The following is a description of a gene set: studied in species Homo sapiens Marker genes curated from the annotated cluster as represented in the Descartes Human Gene Expression During Development database. Human Gene Set: DESCARTES_MAIN_FETAL_PDE1C_ACSM3_POSITIVE_CELLS The gene expression program underlying the specification of human cell types is of fundamental interest. The study authors generated human cell atlases of gene expression and chromatin accessibility in fetal tissues. For gene expression, the study authors applied three-level combinatorial indexing to >110 samples representing 15 organs, ultimately profiling ~4 million single cells. The study authors leveraged the literature and other atlases to identify and annotate hundreds of cell types and subtypes, both within and across tissues. Our analyses focused on organ-specific specializations of broadly distributed cell types (such as blood, endothelial, and epithelial), sites of fetal erythropoiesis (which notably included the adrenal gland), and integration with mouse developmental atlases (such as conserved specification of blood cells). These data represent a rich resource for the exploration of in vivo human gene expression in diverse tissues and cell types. from publication Cao J, O'Day DR, Pliner HA, Kingsley PD, Deng M, Daza RM, Zager MA, Aldinger KA, Blecher-Gonen R, Zhang F, Spielmann M, Palis J, Doherty D, Steemers FJ, Glass IA, Trapnell C, Shendure J (PMID 33184181), and this is the list of marker genes: GSPT2, ZNF85, LINC02241, ANKRD33BP1, FMO6P, ST7L, TNFRSF14-AS1, ZNF480, SLMAP, SRSF3, LINC02935, RN7SL23P, ZNF667 (zinc finger protein 667), VPS45, CCNJ, LIMD1-AS1 (NCBI Gene Id 650067), ZNF350, DLGAP4-AS1, TMEM150B, DBR1, TWSG1-DT, RTF1, CREBBP, LSG1, BRME1, LINC01800, CLDN20, SART3 (NCBI Gene Id 9733), RAB19, ZFR, SCARNA9, VIRMA, ELMO2, LIN28A, DDX4, ZNF512, BRWD1-IT1, RWDD2B, GGACT, MDS2 (NCBI Gene Id 259283), PINLYP, MFSD3, ENSG00000258525, THRB-IT1, UBA2, WNK3 (NCBI Gene Id 65267), PKD1-AS1, TRMT11, SLC16A11 (solute carrier family 16 member 11), H1-10-AS1, CNIH3, LINC00865, ZNF165, PTPRN2-AS1, INO80D, PDXDC2P, ZNF558, ZNF660, ZDHHC3, ARIH1, WDR25, MAMDC2, C3P1, FBN3, DHX37, GUSBP3, SMG1P5 (SMG1 pseudogene 5), HSPA8P15, ZDHHC11B, DPM1, INSRR, C3orf52, ZNF441, IST1, GPRC5D-AS1, FOXP1, OSBPL2, COMMD5, CYP2E1, ZBTB20-AS5, ELP3, RAB43, PTPN23, LINC01852, COL6A4P2, ZNF876P (zinc finger protein 876, pseudogene), RASSF6, FXYD6-FXYD2, TFCP2L1, STPG2, FBXW12, TMEM213, ORC5, FZD4-DT, PDSS2, DDX19B, RPS3AP26, TNPO3, FOXI1, MTMR12, NOX4, RNU6-944P, DUSP22, MAP2K6, SLC25A25, MYSM1, AMACR, RBMS3-AS2, BCRP3, ARHGEF35, TMEM256-PLSCR3, VPS39-DT, OTUB2, MAN2C1, LINC01858, SLC12A9-AS1, THBS4-AS1, ENSG00000235020, GCFC2, ARMC7, PIP4P1, RABGAP1L-IT1, SPATA2L, PER1, HELQ, RPL24P8, C1orf185, FGD6, RPL22L1, HERC2P10, BRICD5, ZNF578, CTPS2, RIPK3, USP19, RARS1, DPH1-AS1, DGKI, TMEM123-DT, CDC73, RPS27P3, LRRC37BP1, RN7SKP176, DNAJC27, CERS3, FAM53B, CARNMT1-AS1, TAF8, LSM6, ALKBH3, CCNT2, KANSL2, PPP3CB-AS1, CHAC2, FRG1JP, DARS1-AS1, ESR2, WDR11, CTF1, TERLR1, MPZL3, MYO1H, MANEA-DT (MANEA divergent transcript), SOX4, LINC02261, EFCAB3, TTC39B, SH2D6, RPS15AP29, POLR2A, GNB1L, LINC01460, COX16, LMTK2, PSMC6, MIR200CHG, SPMIP2, SGSM3, RPL21P135, STIMATE-MUSTN1, PPIEL, CCNK, PRRG2, TGIF2-RAB5IF, ASCL3, PSEN2, VPS51, CEMIP, FOXP1-IT1, EXOSC4, UBQLN1-AS1, LYRM9, ADAM7, TRMT2B-AS1, CHD2, POP4, RPL36A-HNRNPH2, PHC3, MTIF3, CPSF7, SRSF11, SIRT3, YIPF1, RINT1, HHAT, CDAN1, GRIPAP1, ADIRF-AS1, ALDH3A1, AP5B1, TRNT1, ECD, ITGB1-DT, TAF1A, ADAM2, DIS3, CNN3-DT, RBM10, TRAPPC2, ZNF397, ZSCAN21, MUC20-OT1, USP42, TAS2R30, HMGN1P38, ZSWIM1 (NCBI Gene Id 90204), CSKMT (citrate synthase lysine methyltransferase), ZNF202, ZNF503-AS2, TERF1, GMEB2, STAC2, SLIRP, ZNF311, CRYBB2P1, MIEN1, ADAMTSL2, EEF1B2P2, SEC63P1, ARSK, CCDC97, RFXANK, TSPAN16, ANKHD1, C20orf203, BRF1, LACTB, EXOSC3, ZNF776, RMEL3, SUN3, GCDH, FAM53A, MORC2, CD2AP, HSF2, SMUG1, TUT7 (terminal uridylyl transferase 7), MED30, TVP23CP1, MMP25-AS1, LINC02986, IMPA2, B3GAT1-DT, ELF1, PLCG2, CLCNKB, FAM21EP, MFSD6L, PARM1, PET100, MED17, SNTB1, CNNM3, BTG2-DT, ZBTB26, CCDC148-AS1 (CCDC148 antisense RNA 1), STX17, ZNF329 (zinc finger protein 329), SPDYE1, LIN37, TRAPPC13, KCNQ1-AS1, BUD13, TRMT2A, CLEC4C, NMB, MIR200B, LRRC57, ACSM3, PTMAP2, INPP5J, CDC5L, SLC24A1, TADA1, SLC23A3, TIGD7, PEX7, HAUS8, ATPAF1, HHIPL2, STUM, RPL36P6, PNISR-AS1, RAB40B, RNU6-1327P, SDE2, KIAA1210, TRA2B, SRA1, UBAP2L, STARD13-IT1, CASC18, ILRUN, ZNF212, ZNF784, ST20-MTHFS, RPS6KC1, H1-4, APPAT, ZNF346-IT1, MAPKAPK5 (NCBI Gene Id 8550), ALKBH2, USP45, STX16-NPEPL1, ZNF205, KCNG2, ZNF622, STK31, LINC01901, L3MBTL3, TOP3B, KLHL24 (kelch like family member 24, NCBI Gene Id 79965), SULT1C4 (NCBI Gene Id 27233), JMJD8 (jumonji domain containing 8), NDUFB4P11, AIDA, SP2, WARS2, MIOS-DT, PEDS1 (NCBI Gene Id 387521), ZNF484, ATP6V0A4, BRD9, TCF25, HNRNPLL, PLCB4, ZNF274, GOLGA1, TNN, CLNK, ST14, RLF, SNORA80B, LINC01340, KATNA1, SERINC5, ATP6V0D2, TRPV4, RPL22P2, RN7SL105P